The following is a description of a gene set: Catalysis of the transfer of a ubiquitin-like protein (ULP) to a substrate protein via the reaction X-ULP + S = X + S-ULP, where X is either an E2 or E3 enzyme, the X-ULP linkage is a thioester bond, and the S-ULP linkage is an isopeptide bond between the C-terminal glycine of ULP and the epsilon-amino group of lysine residues in the substrate. Human Gene Set: GOMF_UBIQUITIN_LIKE_PROTEIN_LIGASE_ACTIVITY species: Homo sapiens, and this is the list of marker genes: NEURL4, AREL1, MYCBP2, RNF126, CBLC, TRIM56, TRIM24, UBOX5, UBE2C, RNF121 (ring finger protein 121), MYLIP, RNF113A, FBXO17, TRIM59, RNF112, ATG12, RNF13, TMEM129, ARK2N, RMND5B, ZMIZ1, PIAS1, RING1, RNF19A, RFPL1, HLTF, RNF125, ZNRF3, TRIP12, C10orf90, BIRC2, RNFT1 (ring finger protein, transmembrane 1), DTX4, RNF20, TRAIP, UBR3, RNF25, TRIM51, CBLL1, ZNRF2, RABGEF1, RNF144B, VPS11, RNF130, ARIH2, ZNF451, RNF11, TRIM49D1 (tripartite motif containing 49D1), MDM2, HECTD2, MKRN3, CUL4A, HACE1, TRIM6, CUL3, RNF183, MED11, FBXO27, RNF157, FBXO30, RAG1, PEX10, RNF41, RNF6 (NCBI Gene Id 6049), TRIM63, CHFR, SHPRH (SNF2 histone linker PHD RING helicase), TRIML2, PRKN, CUL9, ATG5, WWP2 (NCBI Gene Id 116013), RNF148, TRIM48, RNF10, TRIM49D2, PELI3, DTX3L, EGR2, UBE2O, NOSIP, PCGF5, MEFV, FBXO44, RFFL, TRIM10, TRIM43B, DTX2, BSPRY, ARK2C, MED6, ZNRF1, RNF114, SMURF2, TRIM14, BARD1, UBE3B, MED17, TRIM34, ANAPC11, RNF123, TRIM2, TRIM73, MUL1, TRAF3, PIAS3, TRIM25, CCAR1, XIAP, RNF215 (ring finger protein 215), NHLRC1, IRF2BP1, TRIM39, HUWE1, AMFR, FBXL22, RNF139, TRIM23, PRPF19, MED10, RNF31, RNF217, ZBED1, TRIM50, PEX2, HECW1, TRIM5 (NCBI Gene Id 85363), MARCHF1, RANBP2, RNF213, CBLL2, RNF38, PML, TRIM54, NSMCE1, UFL1, TRAF6, MIB2, DTX1, TRIM52, MKRN1, RNF34, MGRN1, TRIM49, TRIM44, RFPL4A, FBXO6, BIRC3, UBE3C, CBX4, RNF167, ZSWIM2, SIAH2, MARCHF5, RNF170, RC3H1, WSB1, IRF2BPL (NCBI Gene Id 64207), NT5C2, MSL2, PEX12, RNF220 (NCBI Gene Id 55182), ITCH, PJA2, TRIM37, RNF7, RC3H2, TRIM68, MED30, SIAH3, GID4, UBE3D, TRIM69, RNF212B, PDZRN3, UHRF1, UBE2D1, MARCHF2, RFPL2, RNF144A, TRIM55, RNF225, TRIM49B, TRIML1, RNF44, RAD18, RNF152, TRIM58, FBXO2, TRIM49C, SH3RF3, DCST1 (DC-STAMP domain containing 1), RNF111, RNFT2, RNF43, MED21, HERC3 (HECT and RLD domain containing E3 ubiquitin protein ligase 3), HECW2, MED7, SIAH1, DTX3, RNF115, TRIM35, PIAS4, UBE2K, TRIM64B, TRIM43, FBXO4, BRAP, TRIM38, RNF128, ZNF598, RNF216, MKRN2, SMURF1, RNF146, TRAF2, RFWD3, PELI1, UBE4B, RNF135, RNF149, BIRC7, RMND5A, MARCHF7, MARCHF6, BIRC8, TRIM21, TRIM13, NEURL1B, CCNB1IP1, ASB4, UBR1, RNF208, TRIM64, ASB1, BFAR, HERC2, TRIM41, TRIM32, PCGF3, TRIM3, TRIM22, TRIM42, NEDD4, RNF19B, NEURL3, TRIM61, RNF180, MED1, STUB1, HECTD1, MIB1, CDC42, TRIM64C, ZMIZ2, UBE2D3, RNF228, RNF168, RNF181, RNF14, RCHY1, RNF166, MED27, TRIM62, NEDD4L, TRAF7, UBE2F, WWP1, RNF150, WDR24, TRIM7, RNF4, UBR5, TRIM40, TRIM8, UBE3A, RNF40, CBLB, UBR4, LONRF2, PPIL2, TRIM26, TRIM47, ANKIB1, FANCL, MED8, TRIM15, TRIM17, TRIM65, BTRC, UHRF2, ATG3, MED31, RNF26, TRIM28, NCCRP1, TRIM9, RPGR, UBE2D2, MEX3C, HERC5, TRIM31, RNF138, TRIM51G, KCMF1, RFPL3, TRIM4, MARCHF8, TRIM27, RNF5, SH3RF2, TRIM74, SH3RF1, RNF145, RNF2, TRAF3IP2, RNF133, SYVN1, NEURL1, RBBP6, PPP1R11, TRIM60 (NCBI Gene Id 337950), HERC6, UBE4A, HERC4, TRIM45, RNF223, RNF175, UBR2, RNF39, RNF227, TRAF5, NFX1, MED12, FBXO40, MAEA, RFPL4B, DZIP3, TOPORS, RNF186, TRIM71, CBL, ASB12, RNF122, BRCA1, TRIM75, PJA1, ASB2, RLIM, NSMCE2, LRSAM1, RBX1, ZNRF4, TRIM77, PELI2, LTN1, HERC2P3, KIAA1586, TRIM11, RNF185, COP1, PIAS2, ARIH1, NEURL2 (neuralized E3 ubiquitin protein ligase 2), RFPL4AL1, TRIM72, UBR7, RNF8, VPS18, NHLRC3, RNF103